The following is a description of a gene set: species: Mus musculus The directed movement of an amide, any compound containing one, two, or three acyl groups attached to a nitrogen atom, into, out of or within a cell, or between cells, by means of some agent such as a transporter or pore. Mouse Gene Set: GOBP_AMIDE_TRANSPORT, and this is the list of marker genes: Syt9, Npff, Myo5a, Kcnj11, Ucp2, Pde1c, Mup2, Ptprv, Cnr1, Syt7, Cpe, Hmgn3, Ptprn2, Pfkm, Abcg2, Cacna1d, Prkaca, Gpr27, Rac1, Slc25a39, Slc33a1, Ube2q1, Slc25a17, Bad, Pde3b, Il6, Edn1, Disp1, Aimp1, Cplx1, Gnas, Slc38a5, Psmd9, Cdk16 (cyclin dependent kinase 16), Rab3a, Ptprn (NCBI Gene Id 19275), Kiss1, Mup5, Rapgef4, Vgf (NCBI Gene Id 381677), Gltpd2, Plcb1, Tap1, Exoc3l, Fto, Klf7, Prkcb, Stxbp3, Abcb1a, G6pc2, S100a8 (NCBI Gene Id 99591), Ndufaf2, Clock, Abcc2, Mc4r, Sgpp1, Myt1, Abat, Camk2n1, Hmga2, Mttp, Vsnl1, Npy2r, Mlxipl, Tfap2b, Ecrg4, Aqp3, Pick1, Abcc5, Tcirg1, Il1b, F2, Prkce, Crhr1, Drd2, Abca1, Crhr2, Slc25a40, Fga, Fgg, Cltrn, Hcfc1 (NCBI Gene Id 15161), Ghrl, Hmga1, Grp, Tbc1d1, Acsl4, Snx19, Abcc4, Sri, Uts2, Trpm5 (NCBI Gene Id 56843), Adcy8, Stim1, Irs1, Eipr1, Isl1, Hnf4a, Ffar4, Slc38a3, Ppard, Tcf7l2, Tardbp, Sfrp1 (secreted frizzled-related protein 1), Slc46a1, Ucn3, Slc15a3, Chga, Pck2, Hnf1b, Cckbr, Dgat1, Trpv4, Cftr (NCBI Gene Id 547216), Pparg, Rasl10b, Baiap3, Car2, Abca12, Uqcc2, Anxa5, Aqp1, Snord35a, Cplx3, Bmal1, Rims2, Piwil4, Mup4, Chd7, Trpa1 (transient receptor potential cation channel, subfamily A, member 1), Prkd1, Selenot, Adra2a, Kcnq1, Nmu, Brsk2, Nherf1, Gprc6a, Rab8b, Slc16a10, Abcc8, Rph3al, F2rl1, Cask, Abca13, Ffar2, Tfr2, Nlgn2, Fbn1, Stxbp5l, Sytl4, Gip, Nos2, Rptor, Pde8b (NCBI Gene Id 77611), Pla2g6, Rfx3, Slc18a2, Slc25a32, Gnao1, Epha5, Pfkl, Oxct1 (NCBI Gene Id 67041), Plekha8, Hfe, Mafa, Ptbp1, Slc12a1, Kcnb1, Nos1, Ppp3ca, Htr2c, Psap, Cdh17, Slc16a1, Upk3a, Slc25a16, Pax8, Tap2, Cartpt (NCBI Gene Id 27220), Abca2, Mup3, Ucn, Sybu, Gja1, Tm7sf3, Gna11, Map4k4, Cacna1e, Slc15a5, Mir130a, Kcnj6, Sirt4, Acvr1c, Folr1, Cptp, Itsn1, Jak2, Slc25a42, Cd38, Mir200a, Alox5, Mtnr1a, Snord32a (small nucleolar RNA, C/D box 32A), Neurod1, Sidt2, Rbm4, Cckar, Cpt1a, Ccdc186, Pou3f3, Osbp, Nr1h4, Ptger4, Slc30a8, Slc19a3, Gnai1, Gpr119, Glul, Trpv1, Cd74, Rbp4 (retinol binding protein 4, plasma), Sstr5, Tunar, Nnat, Rab11b, C1qtnf12, Ano1 (anoctamin 1, calcium activated chloride channel), Gnaq, Adcyap1, Clcf1, Dio2, Nr0b2, Il1rn, Smpd3, Vapa, Smad2, Lrp2, Park7, Abcb10, Vip, Ghrh, Cacna1c, Slc8b1, Mup11, Ccn3, Slc19a1, Crhbp, S100a9, Agt, Birc5, Prkar1a, Slc26a6, Gipr (NCBI Gene Id 381853), Pask, Inhbb, Atg7, Slc9b2, Ptger3, Sct, Oga, Adcy5, Trpm4, Rfx6, Arrb1, Casr, Stxbp4, Apln, Slc14a1, Nkx6-1, Arhgef7, Slc15a4, Rab1a, Orai1, Irs2, Pex5l, Slc15a1, Snord34, Slc15a2, Hnf1a, Midn, Lepr, Cert1, Itpr1, Nucb2, Dynll1, Gnaz, Aqp7, Kif5b, Mir410, Srebf1, Fkbp1b, Slc27a1, Slc2a2, Mfsd1, Trpm2, Slc16a2, Hmgcr, Capn10, Adora1, Mup1, Slc7a11, Ffar1, Gper1, Ncoa6, Hadh, Ptpn11, Fam3d, Snord33, Hif1a, Fam3a, Stx1a, Gck, Folr2 (folate receptor beta), Slc5a6, Umod, Glud1, Foxa2, Sirt6, Slc14a2, Blk, Sox4, Ghrhr, Pfkfb2, Myh9, Zbed6, Glp1r, Aacs, Sirt1, Gltp (NCBI Gene Id 97217), Rab11fip5, Nadk, Slc25a22, Madd, Gpld1, Anxa7, Slco3a1, Crh, Stx4a, Acvr2b, Jagn1, Tacr2, Snap25 (synaptosomal-associated protein 25), Abcb9, Slc22a8 (NCBI Gene Id 19879), Tiam1, Tnf, Fgb, Eny2 (ENY2 transcription and export complex 2 subunit), Raf1, Cela2a, Rest, Kalrn (kalirin, RhoGEF kinase), Chrm3, Abcd1, Doc2b, Nr1d1, Tnfsf11, Ensa, Pdpn, Ppp3cb, Mcu, Gabbr1, Fam3b, Lrp5, Serp1, Ghsr, Slc13a3, Per2, C2cd2l, Slco1b2, Mgst1, Prkn, Gcg, Cyb5r4, Pim3, Htt, Sirt3, Anxa1, Trpc1, Pdx1, Lif, Ptpmt1, Bglap2, Ffar3, Mmp7, Abcg1, Mtnr1b, Ifng, Ildr1, Abcb1b, Edn3, Abcc1, Lrp1, Ildr2, Pclo, Pltp, Myrip, F2rl2, Egfr, Aqp9, Gpr68, Mpc2, Lep, Gpr39, Pde4c, Rab11fip2, Aqp8, Efna5 (ephrin A5), Foxo1, Ccl5, Lrrc8a, Trh, Slc25a47, Cwh43